Given this list of marker genes DCN, RACK1, ADCY10, PARP1, TRPM4, MLLT11, KDR, P2RX7, ANK3, MYOC, RANGRF, TSPO, CREB1, here is a description of the gene set: Human Gene Set: GOBP_POSITIVE_REGULATION_OF_MEMBRANE_DEPOLARIZATION studied in species Homo sapiens Any process that activates or increases the frequency, rate or extent of membrane depolarization.